Given this list of marker genes TFAP4, CDK5, RELA, GTPBP4 (GTP binding protein 4), NPM1, MAPK8IP1, FBLN1, CDYL, SRCIN1, MINAR1, ZBED3 (NCBI Gene Id 84327, zinc finger BED-type containing 3), HSPA1A, PRKCG, COPS9, LYN, PRKCH, CEP78, CTNNB1, SENP2 (NCBI Gene Id 59343), LATS1, CHMP6, UBE2B, MARCHF6-DT, RB1, N4BP1, NLRP2B, CHP1, UFL1, TSPO, INPP5F, MEN1, KLF15, CDK5RAP1 (CDK5 regulatory subunit associated protein 1), OGT, KLHL31, ACP4, DBI, WNK1, LATS2, SPRY2, DUSP7, TRIM27, CIB1, TTC36, VPS28, PARD3, MGAT4D, PAQR3 (NCBI Gene Id 152559), SMO, MAD2L2 (mitotic arrest deficient 2 like 2), NXN (nucleoredoxin), GNL3L, USP44, GADD45A, SIRT7, PTPN2, PTPRC, CADM4, CORO1C, MACROH2A1, PRKAA2, MAGEA2B, PLAA, CRTAP, BEX3, SFRP2, SFN, PABPN1L, NT5DC2, ITGB1BP1, MIR101-1, SPOPL, AGT, TSG101, FYN, BAG5, HEG1, C9orf72, PARP10, ZGPAT, SERPINB3, DBNDD2, PARK7, WARS1, CRY1, VPS25, DUSP1, PARP14, TPPP, TRAF3IP1, HSPA1B, PTEN, CEACAM1 (NCBI Gene Id 634), FLCN, AKT1, FSCB, CACTIN, AKT1S1, STK38, GSKIP, RPS7, HMG20A, GPRC5A, RPL23, NPPA, CDKN1A, PAK2, ERRFI1, HMG20B, SAMSN1, INCA1, ADGRB1, BEX4, CAMLG, TNFAIP3, YWHAG, THY1, PTPN1, ATG14, RPL11, TRIM21, CDKN2A, SNX6, ARRB1 (NCBI Gene Id 408), ATG5, DEFB114, CDK5RAP3, RGS14, SH3RF2, ADIPOQ, APC, CDKN1B, BEX1, PIBF1, PRKAA1, PPP1R15B, CD300A, TRIM44, PTK6 (protein tyrosine kinase 6), DNAJB2, IBTK, SLIT2, RASSF2, CEP85, DTX3L, DEPTOR (DEP domain containing MTOR interacting protein), ADAR, RPL5, PTPRJ, P3H1, USP4, DNAJC3, PRKDC, PRMT3, BAG2, CAV1, MAGEA2, TAF7, PINX1, IVNS1ABP, UBXN1, IGFBP3, PRR5L, U2AF2 (U2 small nuclear RNA auxiliary factor 2), CNKSR3, DCUN1D3 (defective in cullin neddylation 1 domain containing 3), TARBP2, ZFYVE28, PIAS3, RPS3, MIR138-1, ZC3H12A, RTRAF, PKIA, TERF2IP, INSM1, KLHL40, TAF1 (TATA-box binding protein associated factor 1), SIRT2, MVP, PPIA, ABL1, PTPN22 (NCBI Gene Id 5779), SQSTM1, CEP43, ADARB1, BEX2, CAPN3, PTPN13, SOCS4, MAD2L1, FXYD1, SIRT1, ARRB2, AIDA, FBXO5, APOE, DMTN, CDKN1C, ISG15, GPS2, FKBP8, PPM1E, HDAC8, SVBP (small vasohibin binding protein), PYCARD, HHATL, MAPT, PDCD4, SFRP1, CEP63, HIPK3, SOCS5, PRKCE, PER2, GCLC, DNAJA1, NIBAN1, TARDBP, RASIP1, FRY, MARCHF7, here is a description of the gene set: Any process that stops, prevents, or reduces the frequency, rate or extent of the covalent alteration of one or more amino acid residues within a protein. studied in species Homo sapiens Human Gene Set: GOBP_NEGATIVE_REGULATION_OF_PROTEIN_MODIFICATION_PROCESS